Given this list of marker genes BCL2L1, MAPKAP1, FOXO4, RAF1, FOXO1, AKT1, HSP90AA1, CDKN1A, YWHAG, MLST8, YWHAB (NCBI Gene Id 7529), PRKACA, RICTOR, YWHAQ, SFN, YWHAZ, KPNA1, MAP3K5, GSK3B, AKT2, PDPK1, MTOR, BAD, CASP9, CHUK, SRC, SLC2A4, YWHAE, YWHAH (NCBI Gene Id 7533), CDKN1B, GSK3A, FOXO3, AKT3, TBC1D4, PRKDC, here is a description of the gene set: Human Gene Set: PID_PI3KCI_AKT_PATHWAY Class I PI3K signaling events mediated by Akt from publication Schaefer CF, Anthony K, Krupa S, Buchoff J, Day M, Hannay T, Buetow KH (PMID 18832364) species: Homo sapiens